Given this list of marker genes Fcho2, Dnajc6, Ap2s1, Pacsin1, Picalm, Ap2m1, Clta, Dnm1, Dnm1l, Cltb, Pip5k1c, Myo6, Amph, Ap2b1 (adaptor-related protein complex 2, beta 1 subunit), Snap91, Itsn1, Cltc, Ctbp1, here is a description of the gene set: species: Mus musculus A specialized region of the plasma membrane and underlying cytoplasm which surround the the active zone, into which synaptic vesicle membranes are recycled following exocytosis. It is especially enriched in endocytic proteins following intense activity. Mouse Gene Set: GOCC_PRESYNAPTIC_ENDOCYTIC_ZONE